Given this list of marker genes Pfkfb1, Pgam2, Pfkp, Mpi, Slc4a1, Eno2, Galt, Gpi1, Hk2, Aldoa, Src, Pgk1, Prkaca, Bcl2l13, Foxk1, Pfkfb2, Eno3, Gapdh, Pfkm, Eno1b, Gale, Eno1 (enolase 1, alpha non-neuron), Pkm, Aldob, Tpi1, Ppp2ca, Foxk2, Galk1, Pfkl, Hk1, here is a description of the gene set: The chemical reactions and pathways resulting in the breakdown of a monosaccharide into pyruvate, occurring through a fructose-6-phosphate intermediate, with the concomitant production of ATP and NADH. Mouse Gene Set: GOBP_GLYCOLYTIC_PROCESS_THROUGH_FRUCTOSE_6_PHOSPHATE studied in species Mus musculus